Given this list of marker genes ARG2, SIRPA, IL10, TICAM2, OAS3, MUL1, here is a description of the gene set: studied in species Homo sapiens Human Gene Set: GOBP_NEGATIVE_REGULATION_OF_CHEMOKINE_C_C_MOTIF_LIGAND_5_PRODUCTION Any process that stops, prevents, or reduces the frequency, rate, or extent of production of chemokine (C-C motif) ligand 5.